Given this list of marker genes IRF6, ST14, COBLL1, DYNC2LI1, PRKACA, CDH1, EVC2, FGF3, DLG1, NEK1, MSX1, FGFR2, TP63, ARHGEF38, PRKACB, PAX9, RPS6KA3 (NCBI Gene Id 6197), ARHGAP29, FGFR1, CCBE1, DLX4, WNT10B, EDA, ATR, WNT10A, NAA80, B3GLCT (beta 3-glucosyltransferase), IKBKG, BMP4, TGFA, EDARADD, KAT6A (NCBI Gene Id 7994), PDGFRA, NECTIN1, EVC, GLI1, LRP6, AXIN2, RIC1, SUMO1, here is a description of the gene set: studied in species Homo sapiens Human Gene Set: HP_CONICAL_INCISOR An abnormal conical morphology of the incisor tooth. Conical incisor